Given this list of marker genes Bax, Pax2, Bmp4, Lef1, Zpr1, Cryaa, Xkr8, Vdr, Pml, Six3, Fgf4, Hnf1b, Slit3, Bmp7, Tgfb2, Ppp2r1b, Xkr6, Xkr7, Hand2, Tgfbr3, Spi1, Nkx2-5, Bcl2l11, Cryab, Kcnq1ot1, Jag2, Foxc2, Cdkn2a, Enpp1, Notch1, Bak1, Wt1, Lrp5, Kif1b, Wnt7b, Fzd5, Ccn1, Atf2, Megf10, Chek1, Scrib, Pax8, Xkr4, Tnfrsf1b, Foxc1, Tnfrsf1a, here is a description of the gene set: Mouse Gene Set: GOBP_APOPTOTIC_PROCESS_INVOLVED_IN_DEVELOPMENT studied in species Mus musculus Any apoptotic process that is involved in anatomical structure development.